Given this list of marker genes VPS51, FYN (NCBI Gene Id 2534), CD1D, PHACTR2, ZNF230 (zinc finger protein 230), EGLN2, TRAF3IP2, SPIB, LIPE, EGR1, WNK1, BTG2, CRIM1-DT, IL7, ZNF280B, KAT8, TSHZ1, PTGR3, LCK, SNX25, ASPH, ABHD15, CHCHD7, TPM1, ZNF559, ESYT1 (NCBI Gene Id 23344), LINC01686, CLMN, RTL6, SLC25A37, LINC00880, TLR10, MMGT1, FBXO2 (F-box protein 2), TCEA1, RHOBTB3, MAPK1, HTT, SUMF1, EPB41, NFATC2, MPEG1, GGPS1, CLC, IL18BP, GGA2, AIP, ZNF395, BRD3, FBLN2, PGS1, ARHGAP24, STAT3, RAB40AL, CR1, NAAA, LTBP3, LFNG, RAB11FIP1, PSMC5, RHOH, COTL1, ST14, FAM110A, TBC1D9, ZMAT3, PEPD, TRIM2, RPA1, ZNF134, NPEPPSP1, PCDH8, TOP1MT, CLVS1, PTPN18, FCHO2, COMMD6, ALCAM, NAP1L3, MIR3667HG, CEP85L (centrosomal protein 85 like), SYNGR4, MYH7B, PENK, TRAF5, LAMTOR5, GPM6A, KMT2D, NDFIP1, TPRG1L, PMEPA1, CYB561A3, SIGLEC5, LINC02537, PCSK7, LTB, MTF1, ABI2, CCNQ, PLPP7, PTPN6, BCAS4, EPHX3 (NCBI Gene Id 79852), ORAI3, SMIM29, CCDC92 (coiled-coil domain containing 92), JAM3, REEP5, DSE, ARHGAP35 (Rho GTPase activating protein 35), CASP2, RAI14, IL10RA, LPGAT1, CAPS2, BCL6, BGLAP (NCBI Gene Id 632), WDFY4 (WDFY family member 4), CLSTN1, PDK3, LSG1, PAWR, MROCKI, ADPRH, TNFSF9, EEF1G, RWDD3, SYNPO, MIX23, CECR7, GK5, SPOCK2, IGF2BP3, SHKBP1, NME4, MAN2B2, RIC8B, ZBTB42, DYRK2, MOSMO, RPS6KA2, PRUNE1, CD1C, SLC16A4, PATZ1, ICOS, TMEM273, NECTIN3, KIAA1143, WWC2-AS2, TMEM127, DPH5, SPECC1L, SOX7 (SRY-box transcription factor 7), GNG11 (NCBI Gene Id 2791), GRHPR (NCBI Gene Id 9380), R3HDM2, ATP2A3, WFDC10A, USP44, ARL4A, ZNF880, TP53I13, ZDHHC14, CSK, S1PR4, CBFA2T3, BTBD2, CERS4, PELI3, LINC00623, ASIP, AKT1, DUSP2, ANKRD44, CARNS1, LINC00628, CCDC141, PRKCB (NCBI Gene Id 5579), SMAGP, SLC25A6, RGP1 (NCBI Gene Id 9827), MAGEA3, IER2 (NCBI Gene Id 9592), UNC80, NCF4 (NCBI Gene Id 4689), HIF1AN, FAM200A, PCDHAC2, TSTD2, TRIM41, MGC16275 (NCBI Gene Id 85001), CYTH4, NAPSB, EMB, IL6-AS1, here is a description of the gene set: Human Gene Set: GSE29164_DAY3_VS_DAY7_UNTREATED_MELANOMA_UP from publication Kerkar SP, Goldszmid RS, Muranski P, Chinnasamy D, Yu Z, Reger RN, Leonardi AJ, Morgan RA, Wang E, Marincola FM, Trinchieri G, Rosenberg SA, Restifo NP (PMID 22056381) Myeloid-derived cells comprising the tumor stroma represent a heterogeneous population of cells critical to the structure, function and growth of established cancers. We have recently found that engineering tumor-specific CD8+ T cells to secrete IL-12 (IL-12TD) can lead to striking improvements in T-cell activity against established melanomas in murine models. Surprisingly, IL-12-dependent enhancement of CD8+ T-cell anti-tumor function did not occur through direct ligation of receptors on lymphocytes or NK cells. Instead, IL-12 sensitized host bone marrow-derived tumor-stromal cells, partly through interferon-gamma, to indirectly enhance the effects of adoptively-transferred T cells. Direct presentation of antigen by tumor was not necessary, but MHC class I expression on endogenous cells was essential for IL-12 mediated anti-tumor enhancements. Upon successful treatment with IL-12TD cells, we observed the selective elimination of tumor-infiltrating CD11b+ F4/80+ macrophages, CD11b+/ClassII+/CD11c+ dendritic cells and CD11b+/Ly6C+/Ly6G- but not CD11b+/Ly6C+/Ly6G+ myeloid-derived suppressor cells within regressing lesions. These results are consistent with a model whereby IL-12 triggers the maturation of myeloid-derived cells into competent antigen cross-presenting cells. Licensed recognition of these antigens by effector T cells may in turn trigger the collapse of the tumor stroma and aid in the regression of large vascularized lesions. species: Homo sapiens Genes up-regulated in untreated B16 melanoma: day 3 versus day 7.